Given this list of marker genes Ninj2, Crp, Soat1 (sterol O-acyltransferase 1), Gpr155, Apod, Ptch1, Osbpl8, Osbpl5, Syp, Tspo2 (NCBI Gene Id 70026), Osbp2, Cd81, Stard4 (NCBI Gene Id 77154), Scarb2, Npc1, Osbpl3, Soat2, Gramd1c, Vdac1, Stard6, Npc1l1, Prom2 (prominin 2), Osbpl6, Stard3nl, Pmp2, Minar2, Scap, Scp2, Apoa2, Anxa6, Erlin2, Gramd1a, Vdac2, Prom1, Star, Cyp11a1, Slc38a9, Sidt1, Gramd1b, Npc2, Apoa1, Osbpl7, Nfe2l1, Erlin1 (ER lipid raft associated 1), Osbpl2, Sult2b1, Stard5, Osbpl10, Osbpl1a, Tmem97, Stard3, here is a description of the gene set: species: Mus musculus Mouse Gene Set: GOMF_CHOLESTEROL_BINDING Binding to cholesterol (cholest-5-en-3-beta-ol); the principal sterol of vertebrates and the precursor of many steroids, including bile acids and steroid hormones.